The following is a description of a gene set: Any process that activates or increases the frequency, rate or extent of anion transport. studied in species Mus musculus Mouse Gene Set: GOBP_POSITIVE_REGULATION_OF_MONOATOMIC_ANION_TRANSPORT, and this is the list of marker genes: Cftr (NCBI Gene Id 547216), Abcb1a, Abcb1b, Tcaf1, Trpa1 (NCBI Gene Id 277328)